Given this list of marker genes Cspg5, Septin5, Gpr151, Rph3al, Atp6ap2, Snap29, Slc32a1, Clstn1, Rab3gap1, Tprg1l, Slc4a8, Itsn1, Snx9, Stx11, Prkca, Atp6v0e2, Mff, Dennd1a, Arpc3, Syp, Syt5, Cdk5, Vamp2, Stx1a, Sh3gl2, Ap3d1, Prkaca, Pls3, Mapk10, Nedd4, Grn, Braf, Rab3a, Prkcb, Slc17a6, Nrg1, Fbxo45, Syt17, Sirt2 (sirtuin 2), Rala, Arc, Ctbp2, Rab3b, Eps15, Ston2, Gripap1, Atg7, Syt4, Numb, Ap2s1, Brsk1, Syt10, Ppp3cc, Ap3m1, Prkcg, Tbc1d24, Dvl1, Sptbn2, P2ry4, Bltp1, Ppp3r1, Htr1d, Syn1, Rimbp2, Unc13b, Park7, Atp8a1, Snap23, Syt8, Ppfia3, Snca, Nlgn1, Dnm1l, Rims3, Fmr1, Slc10a4, Pfn2, Abca13, Rac1, Fbxl20, Atp6v1b2 (NCBI Gene Id 97492), Atp6v1d, Sacm1l, P2ry2, Erc1, Snap47, Casp3, Dnm1, Scrib, Dgkq, C9orf72, Dnm3, Iqsec1, Stx19, Stxbp3, Usp46, Bin1, Sv2a, Synj1, Cdh2, Cacna1b, Diaph1, Snap25 (synaptosomal-associated protein 25), Atp6v0c, Dnajc5, Cyfip1, Ncdn (neurochondrin), Snap91, Mkln1, Atp6v1b1, Snapin, Bcl2l1, Fgf14, Slc18a3, Synj2, Unc13a, Ap2a1 (adaptor-related protein complex 2, alpha 1 subunit), Actg1, Canx, Gsg1l, Pacsin1, Napb, Clcn3, Kcnc3, Atp6v0a1, Nedd4l, Pip5k1c, Fcho2, Efnb2 (ephrin B2), Calm3, Cxadr, Syt12, Rock1, Vps18, Ap3m2, Akap5, Syn2, Btbd9, Cplx1, Prepl (prolyl endopeptidase-like), Trim9, Ston1, Pclo, Plaa, P2ry1, Vamp4, Cplx4, Pick1, Sncg, Syt7, Cacnb4, Atp6v1g3, Doc2b, Syt11, Lrp1, Vamp1, Vps35, Pcdh17, Rapgef4, Slc9a6 (NCBI Gene Id 236794), Cltc, Ctnnb1 (catenin beta 1), P2rx7, Ap2a2, Htr1b, Amph, Itgb3, Stxbp1, Calm2, Atp6v1f, Dnm2, Erc2, Rims1, Cacna1d, Stxbp5, Grip1, Calm1, Camk2a, Myo6 (myosin VI), Otof, Rap1a, Ophn1, Eps15l1, Mdm2, Rab11a (NCBI Gene Id 53869), Hap1, Pten, Sv2c, Stxbp2, Rims2, Psen1, Git1, Cacna1a (calcium channel, voltage-dependent, P/Q type, alpha 1A subunit), Rnf220, Vac14, Rab5a (NCBI Gene Id 66987), Atp6v0a4, Stx2, Kcnh1, Rph3a, Npy, Efr3a, Scamp5, Myo5b, Tspan7, Rap1b (RAS related protein 1b), Stx4a, Syn3, Cacna1e, Ap2b1, Sv2b, Rab11fip5, Syt13, Atp6ap1, Npy1r, Doc2a, Slc18a2, Osbpl2, Syndig1, Ctbp1, Th, Atp6v1g1, Atad1, Atp6v1a, Cadps2, Rab7, P2rx2, Necap1, Unc13c, Caly, Syt9, Scrn1, Nrxn1, Atp6v1h, Ap3b2, Stxbp5l, Rnf216, Atp6v1c1, Bsn, Pik3c3, Cblb, Arfgap3, Nlgn3, Syt2, Rabep1, P2rx1, Itsn2, Syde1, Stx1b, Syt6, Ap1s2, Cplx3, Syngr3, Picalm, Nlgn2, Ap3s2, Btbd8, Tor1a, Wnt7a, Hpca, Hip1, Lrrk2, Grik5, Ap3s1, Cdk5r1, Dtnbp1, Prkn, Syt1, Slc18a1, Nsg1, Rims4, Dnajc6, Atp6v1e1, Rab4a, Mx2, Slc2a4, Rab27b, Slc17a7, Rab8a (NCBI Gene Id 17274), Arhgdia, Tamalin, Arf6, Cltb, Lpar1 (NCBI Gene Id 269543), Capn2, Stx3, Cask, Aak1, Git2, Drd4, Ap2m1, Napa, Ddc, Sh3gl1, Actb (NCBI Gene Id 11476), Atp6v0d1, Susd4, Prrt2, Ppp3cb, Atp2a2, Prkar1b, Pld1, Slc17a5, Cadps, Atp6v1g2, Cd24a, Sgip1, Doc2g, Sncb, Slc17a8, Sh3glb2, Ncs1, Magi2, Cplx2, Ppfia2, Drd3 (NCBI Gene Id 13490), Grip2, here is a description of the gene set: Any vesicle-mediated transport that occurs in a synapse. Mouse Gene Set: GOBP_VESICLE_MEDIATED_TRANSPORT_IN_SYNAPSE species: Mus musculus